The following is a description of a gene set: The chemical reactions and pathways resulting in the formation of dopamine, a catecholamine neurotransmitter and a metabolic precursor of noradrenaline and adrenaline. species: Mus musculus Mouse Gene Set: GOBP_DOPAMINE_BIOSYNTHETIC_PROCESS, and this is the list of marker genes: Aldh2, Nr4a2, Epas1, Th, Snca, Agtr1a (NCBI Gene Id 72294), Cyp2d22, Vps35, Park7, Ddc, Gch1, Agtr2, Gpr37 (NCBI Gene Id 269834), Slc6a3, Tgfb2, Dao